The following is a description of a gene set: Human Gene Set: HP_OVARIAN_CYST studied in species Homo sapiens The presence of one or more cysts of the ovary. Ovarian cyst, and this is the list of marker genes: CFAP418, ARL6, EIF4H, SDCCAG8, LIPE, WEE2, NPHP1, LHB, PIK3R1, MKS1, NTHL1 (nth like DNA glycosylase 1), TUBB8, ESR1, NR0B1, SOX3, IFT172, BBS10, STX1A, BBS5, SETD2, PLIN1, PDE11A (NCBI Gene Id 50940), TRPV6, DHX37, CEP290, BBS9, DNAJC30, POR, LMNB2, FOS, INSR, NR5A1, PRKAR1A, TMEM270, PHKG2, PHKB, CEP19, PIK3CA (NCBI Gene Id 5290), CYB5A, GTF2IRD1, TTC8, SDHB, RFC2, SCLT1, BUD23, SLC37A4, MT-CYB, DMRT1, BBS4, OFD1, BBS2, NCF1, GNAS, SOX9, BSCL2, CAVIN1 (NCBI Gene Id 284119), PTEN, FLT1 (NCBI Gene Id 2321), PRLR, FOXL2, SCAPER, SDHD, BBS12, METTL27, CLIP2, ALMS1, VPS37D, ATM, WT1, CYP19A1, AGPAT2, MKKS, PANX1, CYP11B1, IFT74, LIMK1, ELN, PHKA2, CYP17A1, STOX1, STK11, GTF2IRD2, FSHR, AKT2, IFT27, MMP2, CIDEC, CAV1, SRY, KLLN, BBIP1, DHH, BBS1, PLAAT3, F7, TRIM32, TBX1, MSH3, MMP14, FKBP6, GTF2I, LZTFL1, MSX1, WDPCP, PPARG, TBL2, USF3, MAP3K1, CBX2, CORIN, PATL2, SEC23B, ANTXR2, SDHC (succinate dehydrogenase complex subunit C), BAZ1B, HNF1A, LMNA, BBS7, AKT1